The following is a description of a gene set: species: Mus musculus from publication Chen Y, Wang X (PMID 31504780) Genes predicted to be targets of miRBase v22 microRNA mmu_let_7j in miRDB v6.0 with MirTarget v4 prediction scores > 80 (high confidence targets). Mouse Gene Set: LET_7J, and this is the list of marker genes: Hsd3b3, Strbp, Zfyve26, Rbfox1, Tbkbp1, P4ha2, Nectin3, Agap1, Fgd4, Igdcc4, Ccnd2, Tmc7, Snx5, Capn6, Tmem65, Dpysl3, Map4k3, Nfxl1, Eya3, Cebpd, Fasl, Rnf139 (NCBI Gene Id 75841), Utrn, Trhde, Kpna1, Pik3ip1, Asap1, Ndst3 (N-deacetylase/N-sulfotransferase (heparan glucosaminyl) 3), Exoc5, Akain1 (A kinase anchor inhibitor 1), Gxylt1, Cpeb2, Cap1, Arl5a, Hmgcs1, Stxbp5 (NCBI Gene Id 78808), Igf1r, Fbxo30, Gng2, Mtmr12, Crtap, Rock1, Ctdspl2, Nsd3, Zfp516, Bend4, Serinc4, Slc38a9, Zwint, Nap1l1, Loxl4, Slc25a53, Col27a1, Adamts8, Nipal4, Dlc1, Tmem260, Scn3b, Bsn, Slco5a1, Mmp11, Slc30a4, Gabpa, Fndc3b, Igdcc3, Nr6a1, Semp2l2a, Dtx4, Fignl2, Lpgat1, Thoc2, Lilrb4b, Mllt10, Prpf38b, Adamts12, Ints2, Lama1, Rgs8, Sh3rf3, Adamts20, Vstm5, Taf5, Syt1, Rgs16, Nipal1 (NIPA-like domain containing 1), Slc9a9, Pbx3, Arid3a, Zfp644, Pald1, Trim71, Mef2c, Ikzf2, Lrig2, Dusp1, Arhgap12, Galnt2, Cpeb4, Ccnh, Tnrc6a, Rragd, Kdm3a, Peg10, Gdpd1, Pin1, Col4a1, Hk2, Cap2, Gabra6, Ppargc1a, Adipor2, Rslcan18 (NCBI Gene Id 432770), Zswim4, Tmprss11f, Igf2bp3, Entrep2, Cert1, Tab2, Il6, Rab8b, Gramd1c, Dnajb9, Cgn, Mycn, Ppargc1b, Hmga2, Mttp, Fbxl12, Lrrc59, Pkn2, Gramd2b, Pygo2, Stil, Atl2 (NCBI Gene Id 70260), Has2, Mob4, Rcn1, Hectd2, Mex3a, Rorc, Skil, Brd3, Mmd, Lilrb4a, Fras1, Dst (dystonin), Ark2c, Gtpbp2, Cnot6l, Hsd3b2, Ehhadh (NCBI Gene Id 74147), Stard13, Tmprss2, Tspan2, Bcl7a, Slc7a14, Hdgfl3, Dnajc1, Rb1, Tecpr2, Arid3b, Scyl3, Hif3a, Stard3nl, Wdfy3, Cd200r1, Dtx2, Fign, Rab11fip2, Semp2l1, Mnt, Ago4, Limd1, Pou2f1, Plekho1, Inpp5a, Hecw1, Plxnd1, Tenm2, Fndc3a, Lbh, Tstd3, Msi2, Fgf5, Semp2l2b (NCBI Gene Id 638166), Adamts14, Acvr1c, Ypel2, Cd276, Cdc34, Adrb3, Zswim5, Ghr, Onecut2, Ccnd1, Acvr2a, Xkr4, Stx3, Onecut3, Epha3, Cpeb3, Senp2, Egln2, Ston2, Gpcpd1, Btg2, Galnt1, Mycs, Mapk6, Trib1, Syt2, Pxdn, Kif2a, Pcdh20, Tet3, Pappa, Nrk, Rbfox2, Pogz, Fam135a, Col4a2, Stab2, Tm4sf5, Mest, Zfp146, Crem, Zfp455, Trpm6, Galnt12, Adamts15 (ADAM metallopeptidase with thrombospondin type 1 motif 15), Leprotl1, Adcy9, Zc3h11a, Cpeb1, Dzip1, Cacna1e, 9930012K11Rik, Cep164, Atg16l1, Lin28b, Dusp9, Adrb2, Tspan5 (tetraspanin 5), Farp1, Nid2 (NCBI Gene Id 18074), Pcgf3, Ecm2, Col15a1, Il10, Cyth3, Shank2, Ercc6 (excision repair cross-complementing rodent repair deficiency, complementation group 6), Celf5, Zdhhc25, Mon2